The following is a description of a gene set: Genes down-regulated in CD4 T cells over-expressing FOXP3 and PPARg1 isoform of PPARG: GW1929 versus pioglitazone. from publication Cipolletta D, Feuerer M, Li A, Kamei N, Lee J, Shoelson SE, Benoist C, Mathis D (PMID 22722857) Human Gene Set: GSE37534_GW1929_VS_PIOGLITAZONE_TREATED_CD4_TCELL_PPARG1_FOXP3_TRANSDUCED_DN Pioglitazone treatment of CD4+FoxP3- T cells transduced with Pparg and Foxp3 up-regulated a set of genes whose products have been implicated in lipid metabolism pathways. To verify the specificity of this treatment, we performed microarray analysis on Foxp3+Pparg1-transduced CD4+FoxP3- T cells after treatment with other PPARg agonists such as Rosiglitazone (TZD) and GW1929 (non-TZD). studied in species Homo sapiens, and this is the list of marker genes: TOP1, KIF15, RC3H2, RRM1, MAT2B, CYP20A1, MACIR, POLR3E, CNBP, LPAR6, SOCS1, CSGALNACT2, MARCHF6, WARS1, AFF4, TNFAIP1, CCDC90B, MAP2K3, ICAM1, SS18, PCDH9, SLC30A5, KMT5A, APPL2, URB1, EGLN1, CRY1, GRAMD2B, DKK2 (NCBI Gene Id 27123), ITK, G3BP2, SFT2D2, RPS29, CORO2B, INTS5, PWP2, RPL37A (ribosomal protein L37a), RPS6KA3, IFNAR2, KIF1B, SERP1, ZEB2, TRIT1, C2orf42, FBXO5, BECN1, PCGF1, DLC1, MMP9, CIRBP, SSPN, TAF5, STAT3, MAFF, ZNF217, NFKBIB, SEPHS2, SH3TC1, TMEM87A, FBXO46, HIBCH, OSBPL2, SCYL2, KPNB1, GGA3, CNOT4, CXADR, KLC2, CCL7, IL10RB, KCTD14, SAP30, FNBP1, MYBBP1A, GABPB1, ABCC5, LBH, PAN2, CUTC, BRIX1, ZNF804A (NCBI Gene Id 91752), IRF1 (NCBI Gene Id 96501), AVL9, RB1CC1, USP12, OFD1, MRTFB (myocardin related transcription factor B), SGMS1, JUN (Jun proto-oncogene, AP-1 transcription factor subunit), CCNT1, UBXN8, BFAR, SKI, IRX5, MOGS, DEPP1, EID1, TBPL1, NMNAT2, TMEM165, IRF6, MOCOS, SRD5A1, NIBAN1, PRR16, XDH, ATF3, PLEKHF2, KPNA3, HACD1, SRSF10, TNIK, NR1D2, HPGDS, AGPAT5, RALGAPB, TOM1L1, SLC2A3, EMP1, PHKA1 (NCBI Gene Id 5255), HS6ST1 (NCBI Gene Id 9394), MAPK1, PGRMC2 (NCBI Gene Id 10424), GSAP, UBXN7, RELB, SLC4A4, ZC3H12A, SLC36A1, BEX4, NABP1, PRIM2, ZNF267, SIRT1, CXCL9, DYNC1LI2, PAK2, DNAJB5, DUSP5, ITPKC, PIGZ, CYB5A, CARMIL1, PIK3C2B, PLAAT4, PEX13, GCLM, ADNP2, NPY, RLIG1, GABARAP, YBX3, STOM, RFC3, KLHL2, FKBP1A, DENND4A, GPATCH2, RGCC, ANPEP, DMAC2, SKIC8, ZNF239, GATAD2A, CHMP2B, ZDHHC13, UBE2E3, ECI2, CCDC59, CTRL, PIM1, NECAP2, CROCCP2, ST13, SERTAD3, GLO1, GEMIN2 (NCBI Gene Id 8487), NTAN1, FXN, RNF14, GOLT1B, RWDD1, IKZF5, RCL1, NR4A3, TRIM68, NR2F2 (NCBI Gene Id 7026), SOCS6 (NCBI Gene Id 9306), VEGFA, AK4, CDC14B, SCRIB, FAM131A, PEX19, HSPH1, AK5, ZNF609, MIEF1, MAGI2, GALNT3